The following is a description of a gene set: Mouse Gene Set: GOBP_NEGATIVE_REGULATION_OF_INTRACELLULAR_STEROID_HORMONE_RECEPTOR_SIGNALING_PATHWAY Any process that stops, prevents, or reduces the frequency, rate or extent of the activity of any intracellular steroid hormone receptor signaling pathway. studied in species Mus musculus, and this is the list of marker genes: Pias2, Dab2, Cry1, Cyp7b1, Cnot1, Nr0b1, Phb2, Rhoa, Hdac1, Brca1, Cnot3, Zbtb7a, Kank2, Nodal, Lbh, Cnot9, Tcf21, Isl1, Calr, Vps18, Hmga2, Crebrf, Strn3, Trp63, Cry2, Zfp366, Foxp1, Pten, Bmal1 (basic helix-loop-helix ARNT like 1), Sfrp1, Esr2, Clock, Igf1, Vps11, Foxh1, Phb1, Ncor2, Sirt1, Per1, Cnot2, Smarca4, Heyl, Ncor1